Given this list of marker genes SHMT1, POR, CPT1B, CROT, ACADM, CPT1C, CPT1A, TMLHE, CRAT, ALDH9A1, BBOX1 (NCBI Gene Id 8424), CPT2, SLC22A4, ACADL, here is a description of the gene set: The chemical reactions and pathways involving carnitine (hydroxy-trimethyl aminobutyric acid), a compound that participates in the transfer of acyl groups across the inner mitochondrial membrane. studied in species Homo sapiens Human Gene Set: GOBP_CARNITINE_METABOLIC_PROCESS